The following is a description of a gene set: The synthesis of RNA from a DNA template by RNA polymerase III, originating at an RNAP III promoter. Human Gene Set: GOBP_TRANSCRIPTION_BY_RNA_POLYMERASE_III studied in species Homo sapiens, and this is the list of marker genes: MYO1C, CRCP, SNAPC5, ZNF76, GTF3C5, GTF3C3, POLR3F, BRF1, DDX21, IVNS1ABP, BAZ1B, SNAPC2, POLR3K, MAF1 (MAF1 homolog, negative regulator of RNA polymerase III), GTF3C4, MTOR, POLR2K, ZNF143, AR, POLR3GL, GTF3C6, ICE2, POLR3G, ICE1, SF3B1, DHX36 (NCBI Gene Id 96337), RPTOR, ERCC6, POLR2L, PRDX5, DEK, TENM1, POLR3C, NAB2, SNAPC3, SETD5, GTF3C1, RO60, POLR2E, SNAPC1, ZNF345, INHBA, GTF3C2, POLR2F, TBP, POLR1D, POLR3B (NCBI Gene Id 55703), BDP1, CHD8, POLR3A (NCBI Gene Id 11128), POLR3H, POLR3D, SNAPC4, ZC3H8, GTF3A, SMARCA5, BRF2, MYBBP1A, ELL